The following is a description of a gene set: Binding to a stretch of pyrimidines (cytosine or uracil) in an RNA molecule. Mouse Gene Set: GOMF_POLY_PYRIMIDINE_TRACT_BINDING species: Mus musculus, and this is the list of marker genes: Pabpc4l, Rps7, Khdrbs2, Khdc1a, Pabpc1, Pabpc6, Mcrs1, Khdrbs1, Pnpt1, Cpeb2, Hnrnpu, U2af2, Pabpc1l, Pabpc2, Patl2 (protein associated with topoisomerase II homolog 2 (yeast)), Rbms2, Ssb, Cirbp, Atxn1, Msi1, Rbms1, Fmr1, Rbm11, Patl1, Msi2, Ikzf1, Dis3l2, Dazap1, Pabpc5, Pabpc4, Hnrnpc, Rbms3